Given this list of marker genes KSR1, SEMA4A, SMAP1, SCG5, GPN1, MMP10, GGT1, MTHFD2L, AR, HDAC4, EVI2A, ENC1, TSPAN13, KRTAP17-1, ARHGAP31, BCL6, RCAN1, CX3CR1, NCOA1, TNFSF14, ARHGAP5, PDCD1, CST7, PLEKHA5, IL21, CHST15, GPLD1, VIPR1, CD207, RAMP3, NSG2, STK4, FNBP1, PXN (paxillin), P2RX7, SLC29A3, TGFBR3, MED13L, TNMD, PRKD3, USP48, JAK2, SEMA6D, BTLA, SLC7A10, MAP2K7, EMB, PIGN, TTC39C, LIMS4, AMZ1 (archaelysin family metallopeptidase 1), GNPTAB, UBE2E2, CHD8 (NCBI Gene Id 64329), PPTC7, TNFSF13B, CYTH3, CSGALNACT1, PGM2L1, ZNF703, LRP12, LRIG1, RYR1, SHLD1, TRAPPC10, IL2, GRAMD1A, WBP1, DENND2D, RIC1, B3GNT5, TLE4, LGALS3, C19orf38, MFSD6 (major facilitator superfamily domain containing 6), CAPNS1, SERPINB6, ADCY7 (NCBI Gene Id 113), PKP4, NQO2, PDE3B (phosphodiesterase 3B), CD96, CRMP1, PLSCR1, MORC2, SLC25A45, PTPN22, BCKDHA, RNF213, UBE2W (NCBI Gene Id 55284), HSD17B11, CD9, TNRC6C, ENPP2, NRBP1, BCL2A1, TAPT1, CAMTA2, MCEE, RAB11FIP5, MAN2C1, CDK5R1, CASP1, SESTD1, TMEM38B, GOLM1, MAP4K4, MICU3, ZNF846, MDN1 (NCBI Gene Id 23195), SPECC1L, FLVCR1 (NCBI Gene Id 559), PTRH1, RNF144A, NTRK3, ID2, WDFY2 (NCBI Gene Id 115825), EMP1, LYPD6B, TNFSF11, PIP4K2A, NBDY, DPY19L3, ZFP69, FHIP1B, DHRS3, ANKIB1, CHD9, HIBADH, NPEPL1, NSMF, RNF19A, RNF43, TGFBR2, ABHD15, RASSF8, WDSUB1, GPM6B, SMCO4, SYNE1, LBP, PLCB4, HECTD2 (NCBI Gene Id 196026), TCF7, TDRP, AQR, SMARCA2, PPIC, GCNT1 (glucosaminyl (N-acetyl) transferase 1), STAU2, APPL2, TOX2, EGR2, HAUS7, EEIG1, FAM178B, IFT140, CAMK1D, TBC1D2B, SLC25A24, AP1S2, PARP16, SMAP2, EFHD2, FAM120C, POU2AF1, RGS3 (regulator of G protein signaling 3), PANK1, FAM193B, STK32C, BZW2, RNF220, MCOLN2, CALCOCO1, CRACDL, IKZF1, TSHZ1, RNF13, CD200R1, HPCAL1, ETV3, GTF2I, INPP5B, GPD2, TBC1D5, TMEM140, PPP2R2D, PDE7A, ATP7A, RNF11, CYP4V2, SLC25A51, SEMA4F, ABTB3, VAT1L, MARVELD1, STK39, FCHSD2, SLC15A1, here is a description of the gene set: from publication Feuerer M, Hill JA, Kretschmer K, von Boehmer H, Mathis D, Benoist C (PMID 20231436) Regulatory T (Treg) cells that express the FoxP3 transcription factor are essential for lymphoid homeostasis and immune tolerance to self. Other non-immunological functions of Treg cells, such as controlling metabolic function in adipose tissue, are also emerging. Treg cells originate primarily in the thymus, but can also be elicited from conventional T cells by in vivo exposure to low-dose antigen or homeostatic expansion, or by activation in the presence of TGFβ in vitro. Treg cells are characterized by a distinct transcriptional signature controlled in part, but not solely, by FoxP3. For a better perspective on transcriptional control in Treg cells, we compared gene expression profiles of a broad panel of Treg cells from various origins or anatomical locations. Treg cells generated by different means form different sub-phenotypes identifiable by particular combinations of transcripts, none of which fully encompass the entire Treg signature. Molecules involved in Treg effector function, chemokine receptors, and the transcription factors that control them are differentially represented in these subphenotypes. Treg cells from the gut proved dissimilar to cells elicited by exposure to TGFβ, but instead they resembled a CD103+Klrg1+ subphenotype preferentially generated in response to lymphopenia. species: Homo sapiens Human Gene Set: GSE20366_TREG_VS_NAIVE_CD4_TCELL_HOMEOSTATIC_CONVERSION_DN Genes down-regulated in comparison of Homeo Convert versus Homeo Foxp3- (see Table 1S in the paper for details).